Given this list of marker genes CXCL9, PTPN6 (NCBI Gene Id 5777), ANKRD1, CD200, IL1A, MMP3, PABPN1, NLRP7, CTR9, TREM2, STAP1, TRAF6 (NCBI Gene Id 7189), LYN, ZFP36, IRF8, DEFA5, EPHB2, IL1F10, TLR6, ACOD1, LCN2, SHPK, TRIB1, GIT1, IRF3, SCARB1, ASS1, CCL28, BPI, NLRP3, MIR223 (microRNA 223), GATA1, PPBP, SELENOS, CYRIB, DEFB131A, DEFA1B, RHOA, CD36, LACRT, MTDH, IL36G, ABCB1, MAP2K7, IRAK4, KMO, PTAFR (platelet activating factor receptor), ABL1, SIRPA, TNIP2, CD14, TLR1, HMGB2, CMPK2, LDOC1, PDCD4, MIR146A, IRF5, HDAC5, LILRA2, CXCL10, CTSG, MAPK3, DEFA6, TNFAIP3, CD6, MIR6869, CDK19, EFNB2, MAPK8, TNIP3, CSF2, CSF3, BMP6, EDNRB, DAB2IP, MAPK14, HADHB, MIR433, CD180, CXCL13, MIF, SASH1, CXCL8, IL36A, IRAK3, SPI1, PYCARD, CD274, CD55, GBP2, IL12B, DEFB118, PRKCA, SCIMP, PLSCR3 (NCBI Gene Id 57048), GSTP1, HSF1, PDE4B, PLCG2, ADAM9, ZC3H12A, SLC7A5, AICDA, NUGGC, IRAK1, HMGB1, KLRK1, PTPN11, CD68, MALT1, TLR4, TSPO, IL1B, IL36B, FCGR2B, MIR224, CCL27, NOS2 (nitric oxide synthase 2), IL24, LY96, IRAK2, B2M, CDC73 (cell division cycle 73), BCR (NCBI Gene Id 729775), GFI1, AKAP8, TNFSF4, MIR128-1, NFKB1, AKT1, MYD88, AHR, GHSR (NCBI Gene Id 92434), MEF2C, TICAM1, MIR187, NFKBIL1, NR1D1, CCR5, NR1H3, TRIM41, TBXA2R, PF4, UPF1, IL6, TNF, LITAF (NCBI Gene Id 9516), NR1H4, CDK4, DEFA3, SPON2, WNT5A, SBNO2, TICAM2, TRIM5, PF4V1, CACTIN, NOS3, ABCA1, HMGCS2, LTF, CXCL5, CCL2, PRDX2, CARD17P, AXL (AXL receptor tyrosine kinase), TLR5, XBP1, CD86, CX3CL1, DEFA1, IRGM, PLSCR4, IL10, MMP8, OPRK1, IL37, CXCL6, NFKBIA, TLR9, CD80, PPARD, ADAMTS13, PRPF8 (pre-mRNA processing factor 8), LY86, TNIP1, CASP7, MIR19A, MIR20A, TLR10, NR1I2, TNFRSF1B, CASP1, CAMP, CARD8 (caspase recruitment domain family member 8), BCL10, PAF1, CAPN2, GBP5, MIR342, SIGIRR, TIFAB, IL18, VIM, DEFB124, MMP9, MIR766, LILRB1 (leukocyte immunoglobulin like receptor B1), SERPINE1, MIR21, CARD16, NFKBIZ, CEBPE, CHMP5, MIR105-1 (NCBI Gene Id 406897), PTPN22 (NCBI Gene Id 5779), MIR19B1, KLRC4-KLRK1, RELA, HCK, GBP3, ARID5A, MIR140, CX3CR1, MRC1, MAP2K3 (mitogen-activated protein kinase kinase 3), NOD2, TLR2, FCAR, TIRAP, CEBPB, HAVCR2, NFKBIB, MIR17 (NCBI Gene Id 406952), LILRB2, MAPK1, DEFB114, IL36RN, RARA, FZD5, PLAA, DEFA4, JAK2, CD40, PPM1E, PDCD1LG2, PRKCE, RIPK2, LBP, here is a description of the gene set: studied in species Homo sapiens Human Gene Set: GOBP_CELLULAR_RESPONSE_TO_MOLECULE_OF_BACTERIAL_ORIGIN Any process that results in a change in state or activity of a cell (in terms of movement, secretion, enzyme production, gene expression, etc.) as a result of a stimulus by molecules of bacterial origin such as peptides derived from bacterial flagellin.